Given this list of marker genes Misp, Dynlt3 (dynein light chain Tctex-type 3), Mapre3, Ccsap, Mapre1, Kif18b (NCBI Gene Id 70218), Kif18a, Numa1, here is a description of the gene set: Any of the mitotic spindle microtubules that radiate in all directions from the spindle poles and are thought to contribute to the forces that separate the poles and position them in relation to the rest of the cell. species: Mus musculus Mouse Gene Set: GOCC_MITOTIC_SPINDLE_ASTRAL_MICROTUBULE